Given this list of marker genes Atp5f1b, Atp5pb, Atp5f1c, Atp5f1e, Atp5pd, Atp5f1a, Atp5mf (ATP synthase membrane subunit f), Atp5po, Atg5lrt, Atp5pf, Atp5f1d, Atp6-ps, mt-Atp8, mt-Atp6, Atp5mg, Atp5me, Atp6v1a, here is a description of the gene set: studied in species Mus musculus Mouse Gene Set: GOMF_PROTON_TRANSPORTING_ATP_SYNTHASE_ACTIVITY_ROTATIONAL_MECHANISM Enables the synthesis of ATP from ADP and phosphate by the transfer of protons from one side of a membrane to the other by a rotational mechanism driven by a gradient according to the reaction: ADP + H2O + phosphate + H+(in) -> ATP + H+(out).